The following is a description of a gene set: Tyrosine catabolism studied in species Homo sapiens Human Gene Set: REACTOME_TYROSINE_CATABOLISM, and this is the list of marker genes: GSTZ1, TAT, HGD, HPD, FAH